The following is a description of a gene set: species: Mus musculus from publication Tabula Muris Consortium (PMID 32669714) Mouse Gene Set: TABULA_MURIS_SENIS_HEART_VALVE_CELL_AGEING, and this is the list of marker genes: Ndufa4l2, Tmsb10, Tex261, Bcl2l12, Lrrc8a, Wbp2, Ptms, Nr4a1, Ptma, Atp6v0c, Phf1, Sf3b2, Atn1, Fkbp8, Bri3, Gnb1, Ilk, Gm13889, Drap1, Foxs1, Pkig, Srsf5, P2ry12, Sf3b4, Plod2, Mapk8ip1, Junb, Cmtm3, Tomm6, Ap4s1, Plce1, Mast3, Mllt6, Nudc, Polr3gl, Ndfip1, Gcg, Tmem119, Rem1, Ehd4, Ddah2, Ubald1, Ube2j2, Oaz2, Snai1, Lamtor3 (late endosomal/lysosomal adaptor, MAPK and MTOR activator 3), Brd3, Emc10, Kdm6b, Sncg, Stx4a, Frg1, Plp1, Hexb, Fos, Hnrnpl, Prr13, Spry2, Zfhx3, Cystm1, Cend1, Naa80, Map1lc3a, Arl8a, Ctsd, Spry1, Dtx3, Ube2v1, Phlda1, Thra, Castor2, Ngf, Sdhc, Hes1, Trappc6b, Tcf7l1, Oaz1, Cygb, Rhoc, Selenom, Vasp, Mcfd2, Ubb-ps, Vim, Cirbp, Jund, Spr, Txnl1, Cfl1, Gsn, Rbfa, Ednrb, Rcn3, Snrpc, Tsc22d4, Pkdcc, Wnk1, Mesd, Tnfsf12, Apoe, Tle5, Arhgdia, Zfp862-ps, Cd151, Sh3glb2, Anxa5, Secisbp2l, Lgmn (legumain), Dcn, H2-D1, Dpysl2, Tgfb1i1, Gga1, Serbp1, Nkiras2, Pcnp, Rpl13a, Ywhae